Given this list of marker genes Smad3, Foxg1, Ywhaz, Ep300, Foxo6, Sirt1, Foxo3, Sirt3 (NCBI Gene Id 69497), Akt2, Foxo1, Ywhaq, Foxo4, Ywhag, Akt1, Smad4, Akt3, Kat2b, Smad2, Ywhab, Sfn, Atxn3, here is a description of the gene set: FOXO-mediated transcription Mouse Gene Set: REACTOME_FOXO_MEDIATED_TRANSCRIPTION species: Mus musculus